The following is a description of a gene set: studied in species Mus musculus Mouse Gene Set: GOBP_ALTERNATIVE_MRNA_SPLICING_VIA_SPLICEOSOME The process of generating multiple mRNA molecules from a given set of exons by differential use of exons from the primary transcript(s) to form multiple mature mRNAs that vary in their exon composition., and this is the list of marker genes: Rbm5, Rbm24, Rbfox1, Magoh, Rbm8a2, Ddx5, Mbnl1, Rbfox3, Ncbp2, Ptbp1, Rbm15b, Bcas2, Hnrnpm, Hnrnpl, Celf3, Arglu1, Puf60, Cdk13, Pqbp1, Zbtb7a, Hnrnpu, Rnps1, Fmr1, Mbnl2, Hnrnpul2, Rbmx, Slu7, Sap18, Wtap, Rbm11, Ddx17, Sfpq, Nova1, Srsf12, Srsf6, Srrm4, Srsf9 (serine and arginine-rich splicing factor 9), Rbpms, Rbm20, Celf2, Scnm1, Sfswap, Sap18b, Thrap3, Khdrbs2, Rbm7, Strap, Celf1, Rbm17, Dhx9, Tia1, Rbm15, Nsrp1, Celf4, Dyrk1a, Esrp2, Thumpd2, Rbm47, Srsf2, Eif4a3, Arb2a, Rsrc1, Rbmxl1, Hnrnpul1, Rbfox2, Rbpms2, Malat1, Ythdc1, Srsf1, Ncbp1, Rest, Khdrbs3, Smu1, Khdrbs1, Tra2b, Rbm25, Hnrnpa1, Myod1, Rbm4, Esrp1, Nova2, Celf5, Rbm8a, Celf6, Srsf8